The following is a description of a gene set: Genes predicted to be targets of miRBase v22 microRNA hsa-miR-190b-5p in miRDB v6.0 with MirTarget v4 prediction scores > 80 (high confidence targets). Human Gene Set: MIR190B_5P species: Homo sapiens from publication Chen Y, Wang X (PMID 31504780), and this is the list of marker genes: ROCK1, ZNF585A, LMBRD2, CAT, NLGN1, MYO5A, CDKN1B, CDIN1, CLOCK, RBAK, ORC4, TMEM161B, ASAP2, NOLC1, MB21D2, CWC27, TRIM33, TP53INP1, MRS2, ANGPTL1, FNDC3A, PAX3, RBL2, SMC6, CFLAR, TAPBP, HECA, ZDHHC15, CSRNP3, CROT, DMD, CAMK1D, TNRC6B, ADGRE3 (NCBI Gene Id 84658), TNRC6C, TANK, ARPC5, SYNJ1, PHLPP1, PTHLH, AZIN1, PSMA8, NHLRC2, OSBPL6, MYCBP2, TOMM5, BACH2, IKZF2, TRPS1, SEC23A, STK38L, WSB1, NBEA, SAMD4A, DMXL1, VWC2, NBPF12, TCF4, ZBTB41, MEGF10, ADGRA1, ANKRD34A, PAX6, SHANK2, PHF20L1, XRN1, SEC14L1, DOCK9, CSN2, DAG1, CEBPA, KCNB1, KLF15, RCOR1, GPHN, ZSCAN31, MED4, STT3A, FBXO22, WDR44, STK35, TNRC6A, KCNQ5, FGF14, DENND5B, LPCAT2 (lysophosphatidylcholine acyltransferase 2), OPA3, CHD7, YTHDF3, DHRS12, CPOX, MUC17, BCL11A, KCNK9, DEPDC5, CELF4, XPO1, KCNA4 (potassium voltage-gated channel subfamily A member 4), ZNF280D, ZNF529, ERG, SPC25, TBC1D14, IL2, EPC2, NEUROD1, TRIM36, MMAA, TAS2R14, ZNF665